The following is a description of a gene set: Human Gene Set: ZHONG_PFC_C3_ASTROCYTE from publication Zhong S, Zhang S, Fan X, Wu Q, Yan L, Dong J, Zhang H, Li L, Sun L, Pan N, Xu X, Tang F, Zhang J, Qiao J, Wang X (PMID 29539641) studied in species Homo sapiens, and this is the list of marker genes: AGO2, SYT13, RBFOX3, ASIC1, SYP, LINC00342, PTPRU, PCDH11X, CLVS2, BFAR, MAMDC4, JAG2, GNAZ, PHACTR4, PKD1, MAP3K9, EPCAM, CELF5, SETX, POU2F2, FADS3, LETM1, ARHGAP39, ZEB2, XPR1, PSD, SLIT1, AP1G2 (adaptor related protein complex 1 subunit gamma 2), PRKCSH, SYT4, ZNF721, ZBTB8A, PDCD7, NEXMIF, AGO4, ZNF573, CCL5, MAPK11, EEF1A2, JPH4, MDGA1, PCLO, IRF7, NCOR2, SLC26A4, SS18L1, MAFG, MKRN1, ZFP90, CHASERR, PPFIA2, HEATR5A, GAB2, TRIM46, ENC1, NFIX, RGS11, PDP1, SCN3B, RECQL5, LINC00506, SMPD3, NEFM, CHST15, MIAT, RABL6, MAST3 (NCBI Gene Id 23031), ENSG00000291211, ZFTA, NOL4L, NBEA (neurobeachin), SYNGR3, HPCAL4, PACS1, MATCAP1, ACD, CELF2, SLC7A5P2, CNKSR2, USP32P1, CNTN4, PDXP, SYCP2, FLRT2, MGRN1, DPYSL3, AUTS2, ZNF780B, MICAL1, BRSK2, TMEM63C, ELAVL3, DLX1, RIMBP2, BRAP, XPNPEP3, MAPK8IP2, LIMS2, RSPH9, CLDN5, DAAM1 (dishevelled associated activator of morphogenesis 1), ADCY1, AKT3, ULK2, STXBP1, PRDM2, KCTD3, CTTNBP2NL (NCBI Gene Id 55917), PALMD (NCBI Gene Id 93975), RNF112, SHANK2, SPTBN4, L1CAM, SCN3A, CNIH2, FMR1, PNPLA6, SEL1L, SLC1A6, ELAVL2, FBXO41, STRBP, ILRUN, CACNA1B, CDKL2, RUNX1T1, TMEM108-AS1 (NCBI Gene Id 101927455), LRRC7, VSTM2B-DT, CEP164, EPB41L1, ZDHHC8BP, PDE7A, FBN3, CUL9, UNC79 (unc-79 homolog, NALCN channel complex subunit), SNAPC4, THRB, PGM2L1, CHGA (chromogranin A), MEG3, SRRM4, GOLGA7B, STOX2, PHYHIP, SSX2IP, MYCN, TRIM41, ABCC5, GOLGA8A, RIMKLA (NCBI Gene Id 284716), FAM89B, GRIK2, MYO16, ZCCHC12, TUBGCP6, PTCHD4, BASP1, SIN3B, DNM1, CNOT6, SRRM3, CBFA2T3, AFDN, ZNF611, CARMIL3, C2CD4C, ZNF316, FAM131B, SLC38A1, SNAP91, SCN9A, BMPR2, PRKCB, SLC45A1, CHST2 (carbohydrate sulfotransferase 2), KDM4B, CAMK2N2, XKR4, YWHAG, SYT1, VSTM2L (NCBI Gene Id 128434), PDIA2 (NCBI Gene Id 95435), ZNF445, SVOP, RPS6KC1, UBALD2, ACVR2B, ACAP3, CNTN3, LMO7, NPAS1, TSPAN17, CHD5 (chromodomain helicase DNA binding protein 5), GRK3, NHSL3 (NCBI Gene Id 57648), ENTREP3, ATCAY, ME3, PDE1C, EVI5L, FAM193B, ZNF566, IGHMBP2, SPHKAP, MTURN, CACNB3, SLC4A3, IBA57, PRKAR2B, CLCN7, PRRT2, LPAR2, EFR3B, NKAIN1, SLCO3A1, CACNG8, CNTN1, CAPN10, TCAF1, KIAA0319, CCDC120, ARSA, OSBP2, PPP1R12C, RRAGC, CTTN, MEIS3, BIN1, TTC9B, CAVIN4, CALY, SPTBN2, ANKRD44, SLC4A7 (solute carrier family 4 member 7), MAST1, IQCG, DYNC1I1, TMEM44, COL18A1 (collagen type XVIII alpha 1 chain), MMP17, KCTD12, BPTF, PODXL2, STK11IP, NRXN2, ANK3, MEF2C (NCBI Gene Id 4208), BICDL1, RFPL1S, AFAP1, NEAT1, VASH2 (NCBI Gene Id 79805), ZNF362, STXBP6, PPEF1, B4GALNT4, DPYD, RPS6KA3, RFLNB, KCTD7, TSPOAP1, OBSCN, GAS7, RERE, TMEM151B, UBN2, SCG2, MMD, ZNF324, SPIN1, GNAL, PDZD4, MCM4, AGAP2, GOLGA3, SYBU, ADAP1, NLK, DIP2C, SEC31B, MAP6, CACNA1A, EGFL7 (NCBI Gene Id 51162), ANKRD36, PFKP, ARFGEF3, RBM33, KCNT2 (NCBI Gene Id 343450), GAP43, GPR161, CELSR2, CIC, SEZ6L2, CCBE1, CELF6, BAIAP2, GOLGA8B, ZNF37A, STX1A, KCNQ1OT1, DENND6B, TMEM131, GRP, MCM3AP, EDEM3, SEMA3C, CASTOR3P, PTPRS, ATAD2B, TBC1D32, STK11, NCAM1, CYP27C1, LINC02987, RAB3A, MEGF6, SEMA6C, GEMIN5, GIT1, CAMKV, ARPP21, EVL, PLXNA4, PCDH19, GNB3, SH3PXD2A, NPY1R (neuropeptide Y receptor Y1), FGF9, PLPPR1, BAZ2A, VSTM2B, SRCIN1, USP7, NFATC2IP, MCM7, SATB2, NPIPA5, TPTE2P1, CACNB1, GCN1, VPS16, CSK, FBRSL1, SLC25A29, GAD2, ZNF527, CDC42BPB, SMARCA2, NSG2, ANKRD13D, RESF1, CACNA1E, ZNF320, TOM1L2, ST8SIA3, CPLX1, MDN1, IBTK, CNTNAP1, DUSP4, SHTN1 (shootin 1), HRAS, EXD3, PRPF18, NGEF, LPL, DNM3, UBE2Q2P1, CXADR, SYT5, DOT1L, CPNE7, SOX11, HMGA1, ZNF101, RHOU, VARS2, POU6F1, MIR124-1HG, STAG3, CDK5R1, SSTR2, LINC01873, ARK2C, KMT2A, TAF6L, PLXNA3, ARHGAP20